Given this list of marker genes Dsg2, Gfpt2, Ttll4, Arl8b, Ddc (NCBI Gene Id 13195), Rasl11a, H60c (histocompatibility 60c), Scai, Vcpip1, Cenpj, Gstm4, Nova1, Cep85, Rbm25, Dazl, Gabra2, 1110059G10Rik, Trpc6, Rwdd4a, Ttc7b, Snap23, Smok3c, Ssbp1, Bcap31, Dhdh, Ppm1e, Bcr, Pigm, Papolg, Smg1, F2rl2, Trnt1, Ndfip2, Or52n4, Mrps14, Pdcd11, Pik3c2a (NCBI Gene Id 18704), Tbp, Cripto, 9330182O14Rik, Dnajc8, Nefl, Slc45a3, Ccdc137, Ubtfl1, Fgg, Eea1, Zbtb18, Tmc3, Ddx46, Cul3, Tcaim, Etnk1, Myo10, E2f7, Ro60, Capn2, Ube3a, Zcchc9, Slc6a2, Gtf2a1, Tns3, Kpna1, Fam13c, Itgb2, Upf2, Crppa, Wbp11, Mcm6, Fut9, Sestd1, Taf7, BC005537, Adipor1, Epb42, Gm11541, Gpr63, Arhgef28, here is a description of the gene set: Mouse Gene Set: MIR_7668_5P Genes predicted to be targets of miRBase v22 microRNA mmu_miR_7668_5p in miRDB v6.0 with MirTarget v4 prediction scores > 80 (high confidence targets). from publication Chen Y, Wang X (PMID 31504780) species: Mus musculus